Given this list of marker genes Rsph6a, Rsph4a (NCBI Gene Id 212892), Rsph3b, Rsph3a, Rsph1, Rsph9, here is a description of the gene set: Protein complex forming portion of the radial spoke that is orthogonal to the elongated stalk and which projects towards the central pair of microtubules within the ciliary or flagellum axoneme. Mouse Gene Set: GOCC_RADIAL_SPOKE_HEAD studied in species Mus musculus